The following is a description of a gene set: species: Homo sapiens Any process that stops, prevents or reduces the frequency, rate or extent of DNA biosynthetic process. Human Gene Set: GOBP_NEGATIVE_REGULATION_OF_DNA_BIOSYNTHETIC_PROCESS, and this is the list of marker genes: PML, ADIPOQ, POT1, NAT10, EXOSC10, TEN1 (NCBI Gene Id 100134934), DACH1, TERF1, TENT4B, KCNK2, ACD, ANKRD1, HNRNPU, DUSP1, DNAJC2, XRN1, TP53, HNRNPC, HNRNPA1, PINX1, NPPC, CTC1, PARP3, TERF2, DCP2 (NCBI Gene Id 167227), GNL3L, PIF1, STN1, TINF2, CDKN1A, NIBAN2